Given this list of marker genes CDADC1 (NCBI Gene Id 81602), APOBEC3B, APOBEC1, APOBEC3G, APOBEC3C, AICDA, APOBEC2, APOBEC3H, APOBEC3D, CDA, APOBEC3A, APOBEC3F, here is a description of the gene set: studied in species Homo sapiens Catalysis of the reaction: cytidine + H+ + H2O = uridine + NH4 and deoxycytidine + H+ + H2O = deoxyuridine + NH4+. Human Gene Set: GOMF_CYTIDINE_DEAMINASE_ACTIVITY